Given this list of marker genes RHD, MDFIC, NUP88, LZTR1, THSD1, CRLS1 (NCBI Gene Id 54675), here is a description of the gene set: Fetal pleural effusion Human Gene Set: HP_FETAL_PLEURAL_EFFUSION species: Homo sapiens Fetal pleural effusion is the accumulation of excess fluid in the layers of tissue (pleura) lining the lungs and wall of the chest. It may be primary, also termed hydrothorax, occurring as an isolated finding or it may be secondary, most commonly resulting from non-immune hydrops.